Given this list of marker genes WNT4, BMP5, BMP2, DGKQ, NR3C1, H6PD, NR5A2, ATP1A1, DKK3, REST, here is a description of the gene set: Any process that modulates the frequency, rate or extent of the chemical reactions and pathways resulting in the formation of glucocorticoids. Human Gene Set: GOBP_REGULATION_OF_GLUCOCORTICOID_BIOSYNTHETIC_PROCESS species: Homo sapiens